Given this list of marker genes C1QTNF1, PTPRB, IRAK3, C1S, RAPGEF5, PLA2G2D, TIGD2, DST, ALOX5, MMP2, RNF185, XPR1, INSR, IMPACT (NCBI Gene Id 55364), PLA2G15, P2RX7, ZDHHC11, ETV5, SLC28A2, KCNK13, SPATS2L, CCL8, GPR75, KLK11, ADAM15 (NCBI Gene Id 8751), NPL, RASGRP1, CALHM6, LCP2, MERTK, AOAH, MAPK8, HGSNAT (NCBI Gene Id 8119), DENND6A, CXCL13, DUSP7, CFH, CMKLR1, PLEKHG5, LY86, CDC42BPA, TRPV4, MTUS1, GPX2, GBGT1, TBK1, IL10RB, IGF1, LAMC1, HPGDS, HS3ST3A1, EYA4, IGF1R, DMXL2 (Dmx like 2), STAB1, LGALS9, P2RY12, PTGFRN, TM9SF4, DCLRE1C (NCBI Gene Id 64421), TPP1, LRP6, PRMT9, SLCO2B1, TMEM141, GPR146 (NCBI Gene Id 115330), SELENON, PARP14, PSD3, SGCE, SLC1A3, SLC16A7, P2RY6, CSF3R, TPPP, CD84, GNG7, RIPK1, LIFR, WWP1, DPYSL3, VSIG4, ATP6V0D2, SERPINF1, FBXL5, MTNR1B, HOXA11, CCL7, CCL24, TTYH2 (NCBI Gene Id 94015), MAN1C1, PLOD1, TMEM9, ROCK2, IGF2BP3, CTSF, ITSN1, BLVRB, TFPI, TLR8, HS1BP3, IL15, SNX27, CLTC, SNX5, GPX3, CD163, HACD4 (3-hydroxyacyl-CoA dehydratase 4), HPGD, MAF, SNX6, TLR1, ACOX1, GALC, P2RX4, DRAM2, PELI2, FOLR2, NCF2, MFSD11, TMEM37, TMEM59, NUPR1, KCNJ10, FBLIM1, ADAM10, MPP1, SELENOF, GAS7, PDGFC, ABCA9, LAP3, COPZ2, UBE2Q2, CX3CR1, NLRC4, DDX60, GAB1, CMAHP, BANK1, ELF2, LST1, RALGPS2, FAM20C, MGP, POGLUT3, CP, LRRC8A, SCAMP1, TEX12, SERINC3, DPPA3, ETV1, LRRC25, PLD3, DUSP6, OCRL, CTSA, LYVE1, RBSN, DSE, EPO, LGALS8, SLC11A1, HK3, PHYHD1, MAMDC4, POU2F2, TEF, CALCRL, PLXNA4, here is a description of the gene set: Genes up-regulated in cells from Flt3L Melanom injected mice: 33D1+ versus CD4 T cells. Human Gene Set: GSE6259_FLT3L_INDUCED_33D1_POS_DC_VS_CD4_TCELL_UP Dendritic cells (DCs) process and present self and foreign antigens to induce tolerance or immunity. In vitro models suggest that induction of immunity is controlled by regulating the presentation of antigen, but little is known about how DCs control antigen presentation in vivo. To examine antigen processing and presentation in vivo we specifically targeted antigens to the two major subsets of DCs using chimeric monoclonal antibodies. Unlike CD8+ DCs that express the cell surface protein CD205, CD8- DCs, which are positive for the 33D1 antigen, are specialized for presentation on MHC class II. This difference in antigen processing is intrinsic to the DC subsets and associated with increased expression of proteins associated with MHC processing. from publication Dudziak D, Kamphorst AO, Heidkamp GF, Buchholz VR, Trumpfheller C, Yamazaki S, Cheong C, Liu K, Lee HW, Park CG, Steinman RM, Nussenzweig MC (PMID 17204652) species: Homo sapiens